Given this list of marker genes ha70, HA-33, SV2B, botA, SV2C, SV2A, SNAP25, ha17, ntnha, here is a description of the gene set: part of: Neurotoxicity of clostridium toxins Reactome Pathway: Toxicity of botulinum toxin type A (botA) Botulinum toxin type A (botA, also known as BoNT/A), a disulfide bonded heavy chain (HC) - light chain (LC) heterodimer ("dichain"), enters the gut typically as a result of consuming contaminated food, as a complex with nontoxic nonhemagglutinin protein (NTNHA, encoded by the C. botulinum ntnha gene) and multiple copies of three hemagglutinin proteins (HA, encoded by the C. botulinum ha17, ha34, and ha70 genes). The complex protects the toxin from degradation in the gut and mediates its association with the gut epithelium and transcytosis to enter the circulation. Recent studies in vitro raise the possibility that the toxin may also directly disrupt the basolateral membrane of the gut epithelium. Circulating toxin molecules associate with gangliosides and synaptic vesicle protein 2 (SV2) exposed by exocytosis at a synapse of a target neuron in the neuromuscular junction (Yowler & Schengrund 2004; Dong et al. 2006). Vesicle recycling brings the toxin into the neuron where the vesicle is acidified. The lowered pH induces a conformational change in the toxin: its HC forms a passage in the vesicle membrane through which its LC is extruded into the neuronal cytosol and released by reduction of the HC - LC disulfide bond. The cytosolic LC then catalyzes the cleavage of synaptosomal associated protein 25 (SNAP25) on the cytosolic face of the neuronal plasma membrane, thereby inhibiting synaptic vesicle fusion with the plasma membrane and exocytosis. species: Homo sapiens